The following is a description of a gene set: Mouse Gene Set: REACTOME_TP53_REGULATES_TRANSCRIPTION_OF_GENES_INVOLVED_IN_G1_CELL_CYCLE_ARREST TP53 Regulates Transcription of Genes Involved in G1 Cell Cycle Arrest species: Mus musculus, and this is the list of marker genes: Ccne2, Cdk2, Ccne1, E2f8, Ccna2, Cdkn1b, Cdkn1c, Ccna1, Cdkn1a, E2f7